Given this list of marker genes YTHDF3, NCBP2, MIR181D, RACK1, RPS4X, AJUBA, C1QBP, MALSU1, DDX25, MIR101-1, MRPS27, NCK2, MIR218-1, METTL18, EIF2B2, TNRC6C, PRKCA, SHMT2, MKNK2, RPS3, XRN1, EIF3B, EIF4G1, PINK1, MIR125B1, C8orf88, CELF4, NMNAT2, EIF4A2, MIR9-1, DNAJC1, MIR132, DAPK3, TRAP1, EIF5AL1 (eukaryotic translation initiation factor 5A like 1), UPF3B, OTUD6B, SHMT1, PTCD3, HBS1L, TSFM, EIF3H, UQCC2, DHX9, MIR6086, MIR96, AKT1, CNOT8, ELP4, EIF2AK4, MIR346, MIR29C, TNF, RPUSD3, LARP4B, ZFP36L1, METAP1, PPP1R15A, TIA1, MIR103A1, MIR877, CYFIP1, NEURL1, EIF2AK3, MIR1271, GRB7, RPS6KB2, LARP6, MIR28, MIR26B, CNOT9, MIR221 (NCBI Gene Id 407006), SAMD4A, PASK, RPS14, ZNF706, IFRD2, GTDC1, PLD1, POLDIP3, EIF6, MIR874, USP16, NANOS2, YBX1, FOXO3, NGDN, PADI6, METTL8, MIR10B, B3GNTL1, LARP1B, PRR16 (NCBI Gene Id 51334), MIR106A (NCBI Gene Id 406899), RPL26, MTOR, AGO1, MIR106B, ERBB2, ZCCHC4 (NCBI Gene Id 80001), IGF2BP3, MIR365A, UPF1, PRKCH, OGFOD1, MIRLET7A1, BZW2, TACO1, MIR483, SELENOT, MIR210, EIF1B, MIURF, MIR138-1, FASTKD2, NSUN3, EIF4G3, EIF3C, PKM, NCL, OGT, RBM3, MIR939, PKP3, GEMIN5, MIR590, MIR107, CD28, MIR24-1, KBTBD8, SAMD4B, MIR148B, MSI1, DHFRP1, TENT5B, MIR181A2, SCRIB, TRNAU1AP, PUM2, MIR141, AARS1, RIDA, SSB, MIR448, KRT13, MIR200C, MIR200B, MIR19B1, HRURF, DAZ3, EPRS1, AGO4, MIR135B, ELAVL1, FMR1, PKP1, DAZ4, RPS27L, TCOF1, EIF2B5, MIR520E, EIF4E, MIR100, TIFAB, DNAJC3, ZCCHC13, EPHA4, MTG2, AKT2, MIR126, EIF4EBP1, MIR29A, EIF2B4, LIN28A (lin-28 homolog A), TRUB2, RBM4, MIR182, PURA (NCBI Gene Id 5813), MAPKAPK5, IGFBP5, MIR133B, GIGYF2, QKI, DAZL, SERBP1, CNOT6L, HNRNPD, MIR379, RBM4B, PAIP1, RBM24, MIR148A, EIF5A, MIR92A1, THBS1, ZNF598, MIR125A, SHFL, ELP5, MIR499A, NOLC1, DHFR, RNF139, HSPB1, PELO, MIR181C, YBX2, DAPL1, KHDRBS1, SH3BGRL, CAPRIN1, ZFP36, UNK, MIR378A, CPEB1, NAT10, RPS9, HHEX, RCC1L, FXR1, CNOT11, BZW1, METTL5, PYM1, PAIP2, CALR (NCBI Gene Id 811), CSDE1, PA2G4, ENC1, CNOT7 (CCR4-NOT transcription complex subunit 7), MAP3K20, EIF5A2, YTHDF1, SYNCRIP, EIF5B, MIR1-1, ITGA2, MIR27A, MIR98, RGS2, PURB (purine rich element binding protein B), MSI2, CNOT3 (CCR4-NOT transcription complex subunit 3), CASC3, MIR31, CIRBP, ZNF540, ALKBH3, ELP1, TRMT10C (tRNA methyltransferase 10C, mitochondrial RNase P subunit), WTIP, TRIM71, MIR128-1, DDX1, BTG2, ENSG00000293600, PCIF1, LIMD1, TOB1, MIR17, DAZ1, EIF2S1, GZMB, ILF3, GCN1, EIF2AK1, MIR520C, FXR2, PATL2 (NCBI Gene Id 197135), RPL5, CNOT1, EIF4G2, MIR144, MIR345, MRPL13, BARHL2, EEF2, ZAR1L, EIF5, RPL13A, APP, MIR495, MTPN, EIF3K, DHX29, PRMT1, RBMS3, PARP16, SESN2, EEF2K, IGF2BP1, PLXNB2, YBX3, NIBAN1, ANG (NCBI Gene Id 283), DIO2, EIF4E2, CPEB2, LSM14A, CNOT10, CELF1, CDK5RAP1, MIR659, IGF2BP2, BANK1, MIR299, DDX6, INPP5E, PIWIL3, AIRE, IREB2, TNRC6B, MIR298, ELP2, RPL10, GSPT1, MIR15B, EIF2AK2, CCL5, RMND1, RPL38 (NCBI Gene Id 6169), IL6, RPS6KA1, BCL3, HNRNPU, ACO1, CPEB3, GUF1, WT1, MTG1, PRG3, PUS7, PPP1R15B, NPM1, EIF4EBP3, RPUSD4, MIR21, ATXN2, EIF3E, MIR134, MAGOH, EIF4E3 (NCBI Gene Id 317649), ELP3, PIWIL4, ABCE1, CTIF, FASTKD3, NCBP1, SRP9, SARNP, POLR2G, PML, MIR20A, EIF4EBP2, PIWIL1, ALKBH5, NGRN, RPS6KA3, ABCF1, TARBP2, PAIP2B, ZAR1, EIF4ENIF1, DHX36, MIR15A, PPP1CA, NSUN5, AGO2, PRKDC, METTL14, MIR27B, UHMK1, DAP, MTIF2, JMJD4, MIR520B, LRPPRC, DAZ2, EIF2A, YTHDF2, CPEB4, COA3, MIR145, ELP6, DAPK1, AGO3, PIWIL2, TPR, LARP1, RARA, CAPRIN2, MIR204, ETF1 (eukaryotic translation termination factor 1), ALKBH1, METAP2, ZNF385A, MIR29B1, EIF4E1B, NANOS1, LSM14B, MIF4GD, WFS1, UCN, METTL3, DUS3L, MKNK1, CNBP, HABP4, EEFSEC, NANOS3, EIF1, MIR214, MIR146A, KRT17, SECISBP2, APLP1, PABPC1, TNRC6A, MIR181B1, RPS6KB1, EIF4A3, GAPDH, BOLL, DDX3X, CSNK2A1, RBM8A, KLHL25, SARS1, PUM1, SERP1, MIR212, MIR208A, UPF3A, IMPACT, MIR16-1, CNOT2, MPV17L2, MIR503, TYMS, EIF4H, PUM3, MIRLET7I, SEPSECS, ATF4, MIR205, EIF4B, LARP4, NCK1, CNOT6, SMYD5, here is a description of the gene set: studied in species Homo sapiens Any process that modulates the frequency, rate or extent of the chemical reactions and pathways resulting in the formation of proteins by the translation of mRNA or circRNA. Human Gene Set: GOBP_REGULATION_OF_TRANSLATION